The following is a description of a gene set: from publication Chen Y, Wang X (PMID 31504780) studied in species Mus musculus Mouse Gene Set: MIR_380_3P Genes predicted to be targets of miRBase v22 microRNA mmu_miR_380_3p in miRDB v6.0 with MirTarget v4 prediction scores > 80 (high confidence targets)., and this is the list of marker genes: Polr3d, Fggy, Zfp385b, Zfp281 (NCBI Gene Id 226442), Kdm5a, Atp11c, Edil3, Evi2b, Lgals8, Eya1, Tnfaip1, Rab40b, Mctp1, Sfrp1, Apex1, Heca, Zcchc8, Msi2, Klhl29, Slc9a6, Etv5, Col19a1, Kat2b, Spink11, Tasor2, Sp4 (trans-acting transcription factor 4), Efcab7, Trappc11, Nck1, Rbm47, Rimoc1, Cdkl4, Gngt1, Asph, Srsf10, Lage3, Asic5, Bmp4, Actn1, Samd5, Cdyl, Tesk2, Lcmt2, Abcc12 (ATP-binding cassette, sub-family C member 12), Dtd2, Clec9a, Rab39b, Cpeb2, Rc3h2, 4933427D14Rik, Spata1, Cdh7, Pard3, Rap1gds1, Ahrr, Peli1, Mansc1, Cdc37l1, 4930480E11Rik, Nr3c1, Slitrk4 (NCBI Gene Id 245446), Adgrb3, Lrrc59, Mdga2, Ulk2, Plppr5, Utrn, Gins2